The following is a description of a gene set: studied in species Mus musculus Mouse Gene Set: REACTOME_FATTY_ACID_METABOLISM Fatty acid metabolism, and this is the list of marker genes: Mlycd, Cyp4f18, Cyp4b1, Scp2, Them5, Cyp1a1, Dbi, Fasn, Hacd2, Tecr, Acaa2, Ggt1, Acads, Cyp2c66, Hadhb, Cyp1a2, Acacb, Acadl, Nudt19, Alox12b, Cyp4a14, Abcc1, Hsd17b4, Elovl2, Aloxe3, Elovl6, Eci2, Ptges, Prkab2, Acot12, Elovl5, Acbd4, Acox1, Cyp2j6, Aldh3a2, Cbr4, Alox5ap, Prkag2, Pccb, Elovl7, Hsd17b8, Them4, Acoxl, Ptgis, Ppt1, Hacd4 (NCBI Gene Id 66775), Pecr, Hpgds, Acot2, Hadh, Mapkapk2, Eci1, Decr2, Ptgds, Slc25a17, Scd2, Fads1, Crot, Acad10 (acyl-Coenzyme A dehydrogenase family, member 10), Acadm, Dpep2, Acsf3, Lta4h, Pla2g4a, Ndufab1, Pcca, Hacd1, Gpx2, Cyp4f14, Akr1c20, Alox12, Decr1, Ppard, Pon3, Mecr, Cpt1a, Faah, Acbd7, Ggt5, Hao2, Amacr, Ptgs2, Acaca, Hadha, Acot13, Alox5, Tbxas1, Cyp4a12b, Acsbg2, Pon2, Hacd3, Acsbg1, Akr1c21, Hacl1, Thrsp, Acot1, Acot11, Ltc4s, Gpx1, Slc27a2, Mcee, Cyp2c65, Elovl1, Acot4, Acot3, Abcd1, Acox2, Acad11, Acsl5, Ptges3 (NCBI Gene Id 80424), Akr1c6, Tecrl, Cpt1b, Pctp, Acsl1, Cyp4a32, Fads2, Cyp2u1, Cyp4f15, Cyp8b1, Hsd17b12, Ptges2, Rxra, Mmut, Acaa1b, Acbd6, Acot9, Acbd5, Ppt2, Alox8 (NCBI Gene Id 11688), Alox15, Cyp4a30b, Cyp4f40, Morc2a, Hsd17b3, Gpx4, Phyh, Acsl3, Cyp4a10, Crat, Cyp4a31, Echs1 (enoyl Coenzyme A hydratase, short chain, 1, mitochondrial), Ehhadh, Slc22a5, Acsf2, Mcat, Pon1, Acox3, Prkaa2, Mid1ip1, Dpep1, Cyp4a29, Cyp4f39, Acly, Acot7, Elovl3, Cbr1, Cyp1b1, Ptgs1, Acadvl, Slc25a20, Acsl4, Mmaa, Awat1, Acsl6, Cpt2, Cyp4a12a, Ephx2, Acot8, Acot5